The following is a description of a gene set: species: Mus musculus from publication Cui A, Huang T, Li S, Ma A, Pérez JL, Sander C, Keskin DB, Wu CJ, Fraenkel E, Hacohen N (PMID 38057668) Mouse Gene Set: CUI_MIGDC_IL18_RESPONSE_DN Cytokines mediate cell-cell communication in the immune system and represent important therapeutic targets. A myriad of studies have highlighted their central role in immune function, yet we lack a global view of the cellular responses of each immune cell type to each cytokine. To address this gap, the authors created the Immune Dictionary, a compendium of single-cell transcriptomic profiles of more than 17 immune cell types in response to each of 86 cytokines (>1,400 cytokine-cell type combinations) in mouse lymph nodes in vivo. A cytokine-centric view of the dictionary revealed that most cytokines induce highly cell-type-specific responses. For example, the inflammatory cytokine interleukin-1β induces distinct gene programmes in almost every cell type. A cell-type-centric view of the dictionary identified more than 66 cytokine-driven cellular polarization states across immune cell types, including previously uncharacterized states such as an interleukin-18-induced polyfunctional natural killer cell state. Genes negatively differentially expressed in cell type: MigDC (migratory dendritic cell) upon treatment with cytokine: IL-18 in mouse lymph nodes in vivo., and this is the list of marker genes: Rptor, Tmem158, H3f3b, Gtf2a1, Mxd1, Chka, Fosb, Zfp36, Ppp4r2, Synpo2 (synaptopodin 2), Hspa1a, Tmem123, Icosl, Tnfrsf1b, Creg1, Mx1, Tspan3, Kctd12, Slc6a6